The following is a description of a gene set: The process in which a precursor cell type acquires the specialized features of a T cell via a differentiation pathway dependent upon transit through the thymus. studied in species Mus musculus Mouse Gene Set: GOBP_T_CELL_DIFFERENTIATION_IN_THYMUS, and this is the list of marker genes: Skint1, Rag1, Clec4g, Erbb2, Fzd5, Mpzl2, Ctnnb1, Zap70, Srf, Braf, Blm, Tmem131l, Tox, Bmi1, Fas, Bmp4, Cdkn2a, Il1b, Itpkb, Foxp3, Sos1, Mafb, Ncaph2, Ptprc, Stat5b, Zbtb1, Lgals9, Foxn1, Stk11, Il1a, Ada, Aire, Bcl2, Dnaja3, Nfkbid, Zfp609, Gba1, Prkdc, Cd28, Fzd8, Tcf3 (NCBI Gene Id 21423), Apc, Cd3d, Cd3e, Adam17, Mink1, B2m, Abl1, Cd74 (NCBI Gene Id 16149), Nfatc3, Bcl11b, Zc3h8, Ihh, Fadd, Tnfrsf9, Egr3, Ccr6, Ankle1, Lig4, Vnn1, Gli3, Xrcc4, Rasgrp1, Cdk6, Zeb1, Abl2, Atg5, Spn, Ccr7, Rps6, Shh, Jmjd6, Sos2, Ncor1, Il2rg, Adrm1, Zfp36l1, Wnt4, Cd1d1, Zfp36l2, H2-DMa, Adam8, Gata3, Dock2 (dedicator of cyto-kinesis 2), Prr7, Ptpn2, Clptm1, Mr1, Card11, Zfp608, Foxj1, Tespa1, Psmb11, Tnfsf9, Ripk3, Jag2, Ifnar2 (interferon (alpha and beta) receptor 2, NCBI Gene Id 194555), Rag2 (NCBI Gene Id 19374), Nkap, Stat5a, Fzd7, Rabl3, Ripk2, Cd3g, Rorc, Trp53, Wnt1, Il7r